Given this list of marker genes CFLAR, RIPK1, FAS, TNFSF10 (NCBI Gene Id 8743), FASLG, TRADD, CASP8, TNFRSF10A, FADD, TNFRSF10B, TRAF2, here is a description of the gene set: Reactome Pathway: Dimerization of procaspase-8 Procaspase-8 monomers undergo dimerization. The dimerization event occurs at death-inducing signaling complex (DISC) and results in a reposition of the procaspase-8 inter-subunit linker to become accessible for intermolecular processing by the associated procaspase-8 molecule. part of: Caspase activation via Death Receptors in the presence of ligand species: Homo sapiens